Given this list of marker genes RAMAC (NCBI Gene Id 91280), NCBP1, CMTR1, RNGTT, RNMT (NCBI Gene Id 8731), CMTR2, NCBP3 (NCBI Gene Id 55421), RAMACL (NCBI Gene Id 353267), here is a description of the gene set: The sequence of enzymatic reactions by which the RNA 5' cap structure, an inverted 7-methylguanosine linked via a 5'-5' triphosphate bridge (m7G(5')ppp(5')X) to the first transcribed residue, is added to a nascent transcript. Additional methylation can occur on the ribose sugars of the first and second nucleotides adjacent to the m7G nRNA cap. These methylations are often referred to as N6,2'-O-dimethyladenosine (m6,2A) and N6,2'-O-dimethylguanosine (m6,2G), respectively. Human Gene Set: GOBP_7_METHYLGUANOSINE_RNA_CAPPING studied in species Homo sapiens